Given this list of marker genes HACL1, TKTL1, OGDHL, DHTKD1, TKTL2, TKT, ILVBL, OGDH, here is a description of the gene set: Binding to thiamine pyrophosphate, the diphosphoric ester of thiamine. Acts as a coenzyme of several (de)carboxylases, transketolases, and alpha-oxoacid dehydrogenases. species: Homo sapiens Human Gene Set: GOMF_THIAMINE_PYROPHOSPHATE_BINDING